Given this list of marker genes STK26, PLS1, EZR, PODXL, RAPGEF6 (NCBI Gene Id 51735), GLDN, TWF2, ATP8B1, CDHR2, PTPN11, RAP2B, CDHR5, MINK1, RAPGEF2, ESPN, KLF5, MYO1A, RAP2C, VIL1, FSCN1, RAP2A, FXYD5, USH1C, MAP4K4, RDX, TNIK, PLD1, RAP1GAP, RAP1A, RAP1B (NCBI Gene Id 5908), NHERF1, here is a description of the gene set: species: Homo sapiens A process that is carried out at the cellular level which results in the assembly, arrangement of constituent parts, or disassembly of a microvillus, a thin cylindrical membrane-covered projection on the surface of a cell. Human Gene Set: GOBP_MICROVILLUS_ORGANIZATION